Given this list of marker genes Emp2, Cln3, Meox2, Pxn, Kdr, Hrg, Zeb2, Dcn, Igf2, Tbxa2r, Klf4, Atp5f1b, Mir124a-1hg, Robo4, Vegfa, S100a7a, Plpp3, Vstm4, Fbxw7, S100a2, Adam8, Gfus, Atp2b4, Zfp580, Itgb1bp1, Rhoj, Dll4, Amotl1, Jup, Patz1, Rin2, Fgfbp1, Ceacam1, Pecam1, Sema5a, Col18a1, Itgb3, Pik3cg, Zc3h12a, Bsg, Bmp4, Lcn2, Gata3, Tgfbr1, Fgf18, Itgb2, Csnk2b, Met, Amot, Anxa3 (annexin A3), Itgav, Fgf1, Angpt2, Sox18, Prox1 (prospero homeobox 1), Apoh, Lemd3, Sash1, Nfe2l2, Igf1, Gpi1, Rac1, Pdcd10, Nr2e1, Tnf, Angpt4 (NCBI Gene Id 11602), Foxc2, Gpx1, Plekhg5, Nr2f2, Foxp1 (NCBI Gene Id 73231), Hdac5, Fstl1, Map2k3, Prkd1, Grn, Nus1, Stat5a, Mmrn1 (NCBI Gene Id 70945), Mia3, Pik3r3, Cd40, Dicer1, Mef2c, Anxa1, Tmsb4x, Epha2, Akt3, Pik3r2, Sp1, Bmper, Plg, Snai2, Angpt1, Map3k3, Alox12, Cyp1b1 (cytochrome P450, family 1, subfamily b, polypeptide 1), Apoa1, Coro1b, Micall1, Mecp2, Efnb2, Ephb4, Atoh8, Gadd45a, Prkd2, Vegfc, Egr3, P2rx4, Ptk2b, Ccbe1, Nrp1, Tek, Nos3, Fut1, Acvrl1, Itgb1, Clec14a, Atp5f1a, Efna1, Adamts9, Hdac9, Gab1, Adgra2, Synj2bp, Prkx, Gata2, Thbs1, Calr, Prcp, Paxip1, Rhoa, Sparc, Mir218-1, Gpld1, Adam17, Flt4, Card10, Bcas3, Cdh13, Plcg1, Fgf16, Prl7d1, Svbp, Pten, Fap, Pdcd6, Dnaja4 (NCBI Gene Id 80397), Fgf4, Nf1, Stc1, Gipc1, Pik3c2a (phosphatidylinositol-4-phosphate 3-kinase catalytic subunit type 2 alpha), Tgfbr3 (transforming growth factor, beta receptor III), Prkca, Cdh5, Adgrb1, Mmrn2, Rgcc, Bmp10, Fgf2, Spred1, Myh9, Ets1, Hif1a, Fgfr1, Edn2, Srpx2, Robo1, S100a8, Wnt5a, Ptk2, Rab13, Ctnnd1, S2bpcox16, Adtrp, Hspa12b, Emc10, Akt1, Adora2b, Hspb1, Pik3cd, Tgfb1, Ptp4a3, Itgb2l, Slit2, Apoe, Stard13, Cxcl12, Tmem201, Jcad, Egf (epidermal growth factor), Vhl, Gdf2 (NCBI Gene Id 12165), Gm5849, Mir218-2, Lgmn, Prl2c2, Hdac7, Hmgb1 (high mobility group box 1), Ccn3, Plxnd1, Shh, Cxcl13, Smoc2, Pdpk1, Hmox1, Rras, Agt (angiotensinogen), Dpp4, Sirt1, Ager, Ehd4, Rhob (NCBI Gene Id 11852), Ptn, Sp100, Srf, Dab2ip, Sema4a, Pdgfb, Pparg, Pacsin2, Lgals8, Bcar1, Ptprm, Scarb1, Grem1, Abl1, Serpinf1 (NCBI Gene Id 20317), Sh3bp1, Vash1, Nr4a1, Cib1, Loxl2, Notch1 (NCBI Gene Id 68125), Plk2, Krit1, Map2k5, Cxcr4 (C-X-C motif chemokine receptor 4), Wnt7a, Glul, Rock2, Pik3cb, Lpxn, Sec1, Ptgs2, Tns3, S100a9, here is a description of the gene set: The orderly movement of an endothelial cell into the extracellular matrix to form an endothelium. species: Mus musculus Mouse Gene Set: GOBP_ENDOTHELIAL_CELL_MIGRATION